The following is a description of a gene set: FCERI mediated Ca+2 mobilization studied in species Mus musculus Mouse Gene Set: REACTOME_FCERI_MEDIATED_CA_2_MOBILIZATION, and this is the list of marker genes: Plcg2, Ighv6-4, Igkv1-135, Vav3, Nfatc2, Fcer1g, Igkv1-132, Ighv6-6, Ighv8-6 (immunoglobulin heavy variable V8-6), Igkv1-122, Ighv3-8 (immunoglobulin heavy variable V3-8), Btk, Ighv8-13, Igkv8-21, Ppp3r1, Grap2 (GRB2-related adaptor protein 2), Calm2, Txk, Vav1, Ighv5-12-4, Igkv2-109, Ighv6-7 (immunoglobulin heavy variable V6-7), Ighv3-1, Ighv8-4, Igkv2-137, Ighv6-3, Igkv1-99, Ppp3ca, Igkv18-36, Igkv1-110, Igll1 (immunoglobulin lambda-like polypeptide 1), Ppp3cb, Igkv1-117, Shc1, Sos1, Ighv8-2, Calm1, Ighv5-16, Ighv16-1, Igkv15-103, Ighv7-2, Ighv8-5, Ighv6-5, Grb2, Ighv5-9-1, Ighv8-9, Ighv12-3, Ighv13-2, Nfatc3, Ighv3-5, Syk, Calm3, Igkv17-121, Ighe, Igkv11-125, Igkv16-104, Ighv8-11, Igkv1-131, Ighv5-6 (NCBI Gene Id 777780), Ighv8-12, Ighv3-3, Ighv5-4, Vav2, Ighv3-6, Lyn, Igkv1-35, Igkv20-101-2, Ms4a2, Igkv1-133, Lat, Igkv1-88, Plcg1, Iglc1, Igkv2-112, Ighv3-4, Lcp2, Ighv5-2, Fcer1a, Ighv7-3, Ighv5-15, Ighv5-17, Ighv5-12, Itk (NCBI Gene Id 16428), Iglc2, Ighv5-9, Nfatc1, Ighv8-8, Ighv7-4